The following is a description of a gene set: species: Homo sapiens Human Gene Set: GSE11367_CTRL_VS_IL17_TREATED_SMOOTH_MUSCLE_CELL_UP Genes up-regulated in vascular smooth muscle cells: control versus treated with IL17A. from publication Rao DA, Eid RE, Qin L, Yi T, Kirkiles-Smith NC, Tellides G, Pober JS (PMID 19075290) Investigate the effect of recombinant human IL-17A on vascular smooth muscle cells cultured from human aortas., and this is the list of marker genes: RBL1, PTPRU, ESRP2, IGHG3, SETD1B, FARP1, PRRC2A, TMEM89, LRP5, COL14A1, USP26, POGZ, KCMF1, UBAP2, PELI3, TGM1, AGFG1, HOXA13, OBSCN, CBFA2T2, SP2, SAA4, PNMA3, ADAM7, EIF3E, HYAL3, SYT1, UBQLN1, MCTP2, TMEM169, LSAMP, FOXB2 (forkhead box B2), NIBAN3, CACNB3, MARCHF11, ELN, FOXD3, STAT3, USP12, SLC22A25, CSN1S2AP, PRRT1, GTF2I, SPATA2L, LRRC30, ZSWIM2, HECW1, ANO6, SFRP4, ZHX2, SRPRA, COL6A1, PLBD2 (NCBI Gene Id 196463), ERLIN2, DDX54, LRIG3, MC2R, TRIM42, TBX2, TMEM116 (NCBI Gene Id 92920), CABP2, LMOD2, TOR3A, TAFA3, PARVA, AFAP1L1, MYMK, HEBP2, FBRS, AP3B2, TSPAN1, CLCN1, ARIH2, MORN4, MMP20 (NCBI Gene Id 9313), MS4A7, MAT2B, PHOX2B, KCTD1, AMDHD1, NR6A1, PPP3CC, FLRT2, PNMT, TRAM1L1, WRAP73, RNF144A, PRSS27, DSG4, PKD2L2, UCP2, SPATA2, ADAMTS14, TRIM66 (tripartite motif containing 66), WWTR1, CNNM2, SLC1A3, OCLN, LLGL2, FEM1A, UHRF2, MFSD6, MIR151A, CLRN3, TMEM125, DDI1, SCML4, CFAP100, PDIA5, NTN3, MARVELD3, TAPT1, PIEZO2, SLC6A3, SPACA4, BEGAIN, KDM4B, MGAT3, KIF19, ALLC, CCDC70, MYO15A, IQCA1, RALBP1, FAM184A, MATN4, CCDC115, PDZD7, WFDC13, NKX2-2, MYO15B, UBALD1, HCFC1, SUFU, MIR202, ADSS2, PRKAR2A